The following is a description of a gene set: species: Homo sapiens Removes phosphatidylinositol from a membrane or a monolayer lipid particle, transports it through the aqueous phase while protected in a hydrophobic pocket, and brings it to an acceptor membrane or lipid particle. Human Gene Set: GOMF_PHOSPHATIDYLINOSITOL_TRANSFER_ACTIVITY, and this is the list of marker genes: PITPNA, SCP2, OSBPL2, PITPNB, PLTP, C2CD2L, PITPNM3, TNFAIP8L3, PITPNC1, PITPNM1, PITPNM2